Given this list of marker genes DSPP, AMBN, TSC1, IFNG, TSC2, DLX3, ITGB6, COL17A1, LAMB3, ITGB4, here is a description of the gene set: Human Gene Set: HP_DENTAL_ENAMEL_PITS Dental enamel pits The presence of small depressions in the dental enamel. species: Homo sapiens